The following is a description of a gene set: studied in species Homo sapiens Catabolism of skeletal muscle in cachexia Human Gene Set: WP_CATABOLISM_OF_SKELETAL_MUSCLE_IN_CACHEXIA, and this is the list of marker genes: MAPK11, RPTOR, CEBPB, ACVR2A, NFKB2, IKBKB, IL1B, CHUK, TNFRSF1A, PDK1, TNF, IGF1, STAT3, TNFSF12, MSTN, REL, FBXO32, IGF1R, AKT1, NFKB1, SMAD2, FOXO3, EP300, IKBKG, RELB, IL1R1, MAP1LC3A, MTOR, AKT1S1, TRIM63, MLST8, RELA, SMAD4, SMAD3, TNFRSF12A, IL6, JAK1, IL1A, NFKBIA, IL6R